Given this list of marker genes PTGS2 (NCBI Gene Id 5743), MAP4K4, DTX4, IMPDH2, TOM1, HCG4, FBXO28, TXNRD1, IL1RAP, GLA, IWS1, MAMLD1, UBE2A, SNORA74A, DHX36, SLC35F5, CCT6A, ATG13 (autophagy related 13), MREG, MUCL1, ASPHD1, EMD, PYCR3, PSMB5, TFRC, TULP3, SOWAHC, EPPK1, UBTD2, RHOG, PAK1IP1, CASP4, HNRNPC, URB1, MLLT6, NEDD9 (neural precursor cell expressed, developmentally down-regulated 9), RBMX, CS, RRS1 (NCBI Gene Id 90810), SLC25A53, PA2G4, LRRFIP2, PFKFB3, TUBB2A, MGLL, FBXO42, TREML3P, IFRD2, IPO4, TSPAN14, TRIM13, RABGEF1 (NCBI Gene Id 27342), N4BP1, SLC22A3, H2AX, FOSL1, AIFM2, BIN3, ZNF215, FOLR1, H3C8, GOLT1A, FTH1P5, HNRNPA0, YARS1, TBC1D30, COL4A3, BASP1, TSC22D1, CRADD, LIMK2, RELA, ARL8B, ITPRIP, DDX3Y, LYN, CREB3, STK17A, CSGALNACT1, SOSTDC1, SESN2, DNER, TEX46, WDR86-AS1, ZNF625, DAXX, ACTB, PXDC1, GARS1, GPR107, FAM168B, LAMB3, SLC3A2, RDX, CMTM6, ZNF701 (NCBI Gene Id 55762), ADGRA2, CHMP7, CD109, TMA16, SLC6A6, XRCC6, ACSL5, RPL5, PRPF40B, DTX2, RAI14 (retinoic acid induced 14), KIAA1210, UPP1, CDKN2B-AS1, JUNB, FASTK, BOD1, ETS1, LINC-PINT, SLFNL1, CD83, IARS1, CCR5 (C-C motif chemokine receptor 5), ABCF1 (ATP binding cassette subfamily F member 1), DTX1, NOL9, USP47, DCP1A, NABP1, SRC, SPAG9, TRA2B, LINC02139, GABRB2, DDX31, KCTD7, KLHL5, DGCR8, BRD2, DUSP11, FPGS, NUP58, PSKH1, TTC7B, MB21D2, SNAI1, GNL3, SLFN5, UGCG, LINC01592, CASP5, POU2F2, JOSD1, PNO1, FPR1, DNAAF5, ALYREF, SCN1B, TAF3, GRHL1, UBQLN4, COLEC10, ZBBX, HGS, CD40, CHI3L2, CD2, RIN2, MCOLN2, ATP13A3, KHNYN, BANP, TUBB, FABP3, LINGO1-AS1, HAMP, BTG2, NMRAL2P, CXorf58, SERTAD4BP, ABL2, SLC25A31, VMO1, RPGR (retinitis pigmentosa GTPase regulator), NPAP1, CYP2F1 (NCBI Gene Id 1572), TNPO3, ZNF563, ZNF81, LINC00174, SRP54, IGFBP4 (NCBI Gene Id 3487), SFI1, AMPD3, MT1F, PPP1R2 (NCBI Gene Id 5504), CBX5, SLC1A3, PCDH11X, RETREG1, here is a description of the gene set: species: Homo sapiens from publication Hu X, Chung AY, Wu I, Foldi J, Chen J, Ji JD, Tateya T, Kang YJ, Han J, Gessler M, Kageyama R, Ivashkiv LB (PMID 18976936) Genes down-regulated in comparison of macrophages cultured with M-CSF and IFNG versus macrophages cultured with M-CSF and Pam3Cyc. Human Gene Set: GSE11864_CSF1_IFNG_VS_CSF1_PAM3CYS_IN_MAC_DN Gene expression analysis of freshly isolated CD14+ human monocytes and monocytes cultured in the presence or absence of interferon (IFN) -gamma for 24 h and then stimulated with Pam3Cys, a Toll-like receptor (TLR) 2 ligand, for 6 h. Results provide insight into mechanisms by which IFN-gamma reprograms early macrophage differentiation and subsequent response to TLR ligands.